The following is a description of a gene set: Mouse Gene Set: chr17E2 studied in species Mus musculus, and this is the list of marker genes: Gm31759, Gm4708, Gm32282, Gm24126, Gm24475, Dpy30, Ehd3, Gm6276, Gm31818, Gm18068, Gm6496, Gm9316 (NCBI Gene Id 668716), Fam98a, Gm9360, Slc30a6, Gm4711, Birc6, Srd5a2, Crim1, Rasgrp3, Gm31645, Nlrc4 (NLR family, CARD domain containing 4), Galnt14, Capn13, Xdh, Gm31328, D630014O11Rik, Spast, Gm16391, Fez2, Memo1, Ttc27, Gm31235, Gm9349, Yipf4, Gm18366, Rpsa-ps8, Gm9351, E330032C10Rik, Ltbp1, Gm5229 (NCBI Gene Id 383275), Gm4710, Gm4948